The following is a description of a gene set: from publication Schaeffer EM, Marchionni L, Huang Z, Simons B, Blackman A, Yu W, Parmigiani G, Berman DM (PMID 18794802) species: Mus musculus Early prostate development genes (down-regulated at 6 hr dihydrotestosterone) which are also down-regulated in localized vs metastatic prostate cancers. Mouse Gene Set: SCHAEFFER_PROSTATE_DEVELOPMENT_AND_CANCER_BOX4_DN Cancer cells differentiate along specific lineages that largely determine their clinical and biologic behavior. Distinct cancer phenotypes from different cells and organs likely result from unique gene expression repertoires established in the embryo and maintained after malignant transformation. We used comprehensive gene expression analysis to examine this concept in the prostate, an organ with a tractable developmental program and a high propensity for cancer. We focused on gene expression in the murine prostate rudiment at three time points during the first 48 h of exposure to androgen, which initiates proliferation and invasion of prostate epithelial buds into surrounding urogenital sinus mesenchyme. Here, we show that androgen exposure regulates genes previously implicated in prostate carcinogenesis comprising pathways for the phosphatase and tensin homolog (PTEN), fibroblast growth factor (FGF)/mitogen-activated protein kinase (MAPK), and Wnt signaling along with cellular programs regulating such 'hallmarks' of cancer as angiogenesis, apoptosis, migration and proliferation. We found statistically significant evidence for novel androgen-induced gene regulation events that establish and/or maintain prostate cell fate. These include modulation of gene expression through microRNAs, expression of specific transcription factors, and regulation of their predicted targets. By querying public gene expression databases from other tissues, we found that rather than generally characterizing androgen exposure or epithelial budding, the early prostate development program more closely resembles the program for human prostate cancer. Most importantly, early androgen-regulated genes and functional themes associated with prostate development were highly enriched in contrasts between increasingly lethal forms of prostate cancer, confirming a 'reactivation' of embryonic pathways for proliferation and invasion in prostate cancer progression. Among the genes with the most significant links to the development and cancer, we highlight coordinate induction of the transcription factor Sox9 and suppression of the proapoptotic phospholipid-binding protein Annexin A1 that link early prostate development to early prostate carcinogenesis. These results credential early prostate development as a reliable and valid model system for the investigation of genes and pathways that drive prostate cancer., and this is the list of marker genes: Eif2ak2, Zfp664, Prpf40a, Vps36, Ier2, Hnrnpc, Zfp462, Tob2, Smarca2, Ier3ip1, Gcc2, Nfia, Bclaf1, Lrpap1 (NCBI Gene Id 97224), Elovl5, Sympk, Csnk1a1, Srsf9, Chd9, Manf, Nrip1, Tnrc6b, Canx, Ssr1, Sfpq, Cdc37l1, Rest, Tmed2, Psmc6, Ctso (NCBI Gene Id 99547), Myo1b, Pphln1, Eif3a